The following is a description of a gene set: The chemical reactions and pathways resulting in the breakdown of N-acetylneuraminate, the anion of 5-(acetylamino)-3,5-dideoxy-D-glycero-D-galacto-non-3-ulosonic acid. Human Gene Set: GOBP_N_ACETYLNEURAMINATE_CATABOLIC_PROCESS studied in species Homo sapiens, and this is the list of marker genes: GNPDA2, RENBP, NAGK, AMDHD2, GNPDA1, NPL